The following is a description of a gene set: Mouse Gene Set: GOBP_DIENCEPHALON_MORPHOGENESIS The process in which the anatomical structures of the diencephalon are generated and organized. The diencephalon is the paired caudal parts of the prosencephalon from which the thalamus, hypothalamus, epithalamus and subthalamus are derived; these regions regulate autonomic, visceral and endocrine function, and process information directed to the cerebral cortex. species: Mus musculus, and this is the list of marker genes: Otx1, Otx2, Prop1, Duox2, Wnt5a, Sox2